Given this list of marker genes Srp54c, Srp54a, Srp14, Srprb, Zfand2b, Ssr3, Srp9, Tram1l1, Sec61b, Srp19, Srp68, Sec61a1, Sec61a2, Srp72, Arl6ip1, Srpra, Tram1, Sec63, Tram2, here is a description of the gene set: species: Mus musculus The targeting of proteins to a membrane that occurs during translation. The transport of most secretory proteins, particularly those with more than 100 amino acids, into the endoplasmic reticulum lumen occurs in this manner, as does the import of some proteins into mitochondria. Mouse Gene Set: GOBP_COTRANSLATIONAL_PROTEIN_TARGETING_TO_MEMBRANE